Given this list of marker genes Bax, Prkdc, Bcl2l1, Ube2b, Rhox5 (NCBI Gene Id 18617), Ybx3 (NCBI Gene Id 56449), Kit, Syce3, Il1a, Il1b, Kitl, Unc5c, Mael, Insl6, Ddb1, Casp4, Topaz1, Tex11, Sycp2, Lrriq1, Casp2, Sod1, here is a description of the gene set: Mouse Gene Set: GOBP_ECTOPIC_GERM_CELL_PROGRAMMED_CELL_DEATH studied in species Mus musculus Programmed cell death of an errant germ line cell that is outside the normal migratory path or ectopic to the gonad. This is an important mechanism of regulating germ cell survival within the embryo.